The following is a description of a gene set: In approximately 70% of patients with hepatocellular carcinoma (HCC) treated by resection or ablation, disease recurs within 5 years. Although gene expression signatures have been associated with outcome, there is no method to predict recurrence based on combined clinical, pathology, and genomic data (from tumor and cirrhotic tissue). We evaluated gene expression signatures associated with outcome in a large cohort of patients with early stage (Barcelona-Clinic Liver Cancer 0/A), single-nodule HCC and heterogeneity of signatures within tumor tissues. Human Gene Set: MINGUEZ_LIVER_CANCER_VASCULAR_INVASION_UP Genes over-expressed in hepatocellular carcinoma (HCC) with vascular invasion. from publication Villanueva A, Hoshida Y, Battiston C, Tovar V, Sia D, Alsinet C, Cornella H, Liberzon A, Kobayashi M, Kumada H, Thung SN, Bruix J, Newell P, April C, Fan JB, Roayaie S, Mazzaferro V, Schwartz ME, Llovet JM (PMID 21320499) species: Homo sapiens, and this is the list of marker genes: CPD (carboxypeptidase D), PGLS, XPOT (NCBI Gene Id 11260), UBE2C, YY1AP1, TYMS, GORASP2, NARF, CD24, NOMO2, CDKN3, NDUFS8, HDLBP, KDELR1